The following is a description of a gene set: Mouse Gene Set: GOBP_REGULATION_OF_CATABOLIC_PROCESS species: Mus musculus Any process that modulates the frequency, rate, or extent of the chemical reactions and pathways resulting in the breakdown of substances., and this is the list of marker genes: Dapk1, Rnasel, Trim32, Rad23a, Rnf31, Gpr137b, Ythdf1, Usp25, Rybp-ps, Gsk3b, Ddit4, Mettl1, Myd88, Slfn2 (NCBI Gene Id 20556), Bag3, Lrsam1, Oaz3, Hmox1, Srebf1, Tecpr1, Amer1, Bag5, Pik3c3, Itch, Snx30, Larp4b, Senp1, Trib3, Eif2ak3, C9orf72, Dcp1a, Mir196a-1, Sqstm1, Caml, Snx4, Tent5c, Usp33, Asb5, Kat2b, Rab39b, Fbxl4 (NCBI Gene Id 269514), Vps28, Sh3rf1, Atg16l1, Ier3, N4bp1, Ikbke, Bcl2l11, Gnai3, Adra1b, Gsk3a, Elapor1, Eif2ak1, C4bp, Pip4k2b, Zc3h12d, Nudt15, Fbxl20, Mir451b, Ndfip1, Hnrnpc (NCBI Gene Id 28125), Xbp1, Tspan17, Zfp418, Psmf1, Cttn, Hipk2, Irak3, Cdkn1b, Traf3ip2, Pttg1ip, Ikbkg, Tlr9, Araf, Hspa1b, Atm, Akt1, Il10, Bnip3, Pkp1, Kat5, Ins1, Magoh, Pik3c2a, Pabpn1l, Tmtc3, Mir7578, Psen1, Snx1, Chfr, Ubqln1, Xpa, Cidea, Pnldc1, Plekhg5, Tent4a, Ptk2b, Tbk1, Ripk2 (receptor (TNFRSF)-interacting serine-threonine kinase 2), Wnk1, Nos2, Phkg1, Atg2a, Agap2, Nrde2, Moap1, Trim39, Pfkfb1, Mir451a, Bnip3l, Hsf1, Mad2l1, Rab7, Cpt1a, Tfeb, Mov10, Klhl22, Adam8, Dab2ip, Nkd2, Fhit, Fastkd1, Wdr6, Trim30a, Gata4, Fyco1, Anxa2, Rufy4, Slirp, Apc, Dcaf1, Pan2, Rchy1, Prkaa2 (protein kinase, AMP-activated, alpha 2 catalytic subunit), Hnrnpd, Ybx1, Zc3hav1, Trim3 (tripartite motif-containing 3), Nop53, Sec22b, Pias4, Pin1 (peptidyl-prolyl cis/trans isomerase, NIMA-interacting 1), Eif4a3l2, Bag2 (NCBI Gene Id 74827), Sgsm3, Dnm1l, Cacng7, Snx33, Adrb2, Psmd10, Msn, Abca2, Usp14, Tomm7, Csnk2a1, Trim71, Smarcc1, Samd9l, Hdac4, Atg12, Sf3b3, Ube2k, Sik2, Fmr1 (fragile X messenger ribonucleoprotein 1), Mir196b (NCBI Gene Id 723820), Igf2bp1, Lepr, Rragd, Sesn1, Pik3cg, Rbm38, Pkd1, Ager (advanced glycosylation end product-specific receptor), Rgp1, Zp3r, Trp53inp1, Trdmt1, Tent5a, Vgll4, Pbk, Pim2, Rbx1, Tmem168, Src, Traf7, Ythdf3, Tgfb1i1, Faf1, Fbxl2, Agbl4 (ATP/GTP binding protein-like 4), Csnk2b, Pabpc4, Serpine2, Cop1, Trim21, Fus, Lrrk2, Clu, Prxl2c, Fastk, Dact1, Tnfrsf1b, Cbfa2t3, Atg5, Mtm1, Eif4enif1, Mdm2, Rnf19a, Tigar, Det1, Hspb8, Herc1, Ubr4 (NCBI Gene Id 97189), Pptc7, Depp1, Apoc3, Endog, Dhx36 (NCBI Gene Id 99809, DEAH-box helicase 36), Pink1, Fastkd2, Rhbdd1, Abcb11, Nupr1, Cnot1, Nbas (NCBI Gene Id 71169), Ecscr, Ufl1, Rnf5, Ep300 (NCBI Gene Id 328572), Secisbp2, Mfsd8, Becn1, Rdx, Pcsk9, Adgrb1, Pkp3, Zfp36l3, Samd4, Bcl2, Kat8, Larp1, Pias1, Csnk2a2, Nanos1, Dysf, Tnrc6b, Smad4, Lrp1 (NCBI Gene Id 16971), Pum1, Sumo1, Tspo, Plk1, Apoc1, Aifm1, Srsf1, Hamp2, Zc3h18 (NCBI Gene Id 76014), Mir466l, Syncrip (NCBI Gene Id 78260), Socs4, Mtcl3, Supv3l1, Paqr3, Mlxipl (NCBI Gene Id 58805), Prkce, Fastkd3, Egfr, Disc1, Vegfa (vascular endothelial growth factor A), Mtor, Apex1, Nrg1, Igf2bp2, Nod2 (nucleotide-binding oligomerization domain containing 2), Noct, Dda1, Slc25a4, Cnr1, Rbm33, Ncor1, Dcps, Washc1, Klhl17, Wnt1, Tirap, Park7, Atf6, Fbxw7, Sirt6, Tardbp, Rps7, Ddit3, Lep, Pabpc1, Trf, Upf1, Usp38, Sh3rf2, Brf1, Dtl, Trim23, Ctsa, Oaz2, Styx-ps, Rnft2, Zfp36l1, Cd81 (NCBI Gene Id 12520), Setd2, Acacb, Ubqln2, Pacsin3, Atp5if1, Pcid2, Rhbdd3, Phf20l1, Tmem259, Tent4b, Pnpt1, Pnpla2, Phax, Rhbdf1, Egln1, Snx3, Smo, Ldc1, Pin1rt1, Trex1, Upf3a, Azin1, Psme3ip1, Vps35, Mycbp2, Psmd1, Dicer1, Mapt (NCBI Gene Id 17762), Cnot7, Igf1 (insulin-like growth factor 1), Wac, Ttc36, Tom1, Odc1, Prickle1, Ddb1, Sh3glb1, Wdr24, Sufu, Hcar2, Dffb, Sct, Lsm1, Stk38l, Twist1, Glmn, Slc4a4, Cul4b, Sco1, Jmjd8, Dapl1, Shh, Slc2a6, Cav1, Laptm4b, Phf23, Fbp1, Crebrf, Gata5, Optn, Daglb, Hsd11b1, Nsun2, Rbm47, Usp20, Mtdh, Zbtb20, Foxk2, Ambra1 (autophagy/beclin 1 regulator 1), Slc25a5, Gpc3, L3mbtl3, Angel2, Qrich2, Igtp, Etfbkmt, Mapkapk2, Parl, Rubcn, Abcd2, Mapk8, Tob1, Ptpn22, Ppp1r3d, Mlx, Atxn3, Prr5l, Sh3bp4, Gtsf1 (NCBI Gene Id 74174, gametocyte specific factor 1), Trem2, Nanos3, Tut7, Bmal1, Bmf, Mlycd, Acer2, Ldlr, Mtcl2, Usp13, Lrpprc, Ulk3, Gigyf2, Tbc1d25, Adra1a, Pten, Tmem9, Prmt6, Grin2c, Eif4g1, Egln2, Plk3, Svip, Sirt1, Snca, Nub1, Sirt2, Ubb, Rragb, Grsf1 (NCBI Gene Id 97246), Ttc5 (tetratricopeptide repeat domain 5), Fxr1, Axin1, Nnt, Trim65, Btrc, Sgta, Uchl5, Atg4b, Taf9, Rnft1, Nedd4, Casp1, Alk, Fmc1, Gtpbp1, Elavl4, Il6, Hpgd, Wnt5a, Adam9, Apoa4, Nampt, Bok, Atg7, Rock2, Zar1, Samd4b, Foxf2, Wdr41, Pcbp4, Hsp90aa1, Psme3, Cpeb3, Tmx1, Naf1, Cul4a, Gfap (NCBI Gene Id 14580), Ulk1, Socs5, Nkd1, Asb9 (NCBI Gene Id 69299), Dcn, Obp2a, Lonp2, Smurf1, Tpcn2, Zdhhc19, Sumo2, Dkc1, Hsp90ab1, Cidec, Slc4a1 (solute carrier family 4 (anion exchanger), member 1), Trib2, Psme2, Ifnb1, Fzr1, Esrrb, Dele1, Phka1, Kcne2, Polr2g, Nell1, Aurka, Phkg2, Flna, Actn3, Mtcl1, Aadac, Mex3d, Htra2, Cdh1, Trim13, Pan3, Dcaf12, Atg101, Csdc2, Apoa5, Serpinb1a, Gba1, Rab26, Apoe, Cers1, Cisd1, Dtx3l, Usp9x, Adra2a, Endou, Patl2, Pycard, Ppp1ca, Ptpn3 (NCBI Gene Id 545622), Piwil4, Mtln, Dnaaf4, E330034G19Rik, Tmf1, Rnf41, Lzts1, Elavl1, Itgb1, Ddrgk1, Trim67, Eif2a, Rptor, Atp6v0a1, Prkaca, Tpcn1, Npc1, Mettl14, Rmc1 (NCBI Gene Id 76482), Klhl40, Vps13c, Zc3h12a, Bag6, Usp30, Mettl3, Fkbp8, Apoh, Pde3b, Phb1, Prkag2 (NCBI Gene Id 73700), Zdhhc2, Ogt, Ppp1cb, Pde12, Tent5d, Mapk9, Idh1, Cnot2, Gja1, Usp8, Fmn2, Snx9, Pik3r2, Tut4, Rpl23, Wfs1, Il10ra, Prkd1 (protein kinase D1), Plin5, Usp26, Zfp36, Fap, Pip4k2c, Adora1, Rbm8a2, Rbm10, ENSMUSG00000144291, Gimap5, Il3, Ticam1, Fxr2, Dab2, Pik3r4, Ercc4, Tbc1d14, Prkaa1, Nlrp5, Ppara, Chuk, Cul3, Cptp, Qsox1, Zkscan3, Npm1, Alkbh5, Celf1, Zer1, Pip4k2a (phosphatidylinositol-5-phosphate 4-kinase, type II, alpha), Cdc37, Lats1, Rc3h2, Poldip2, E2f1, Thrap3, Foxo3, Scarb1, Golga2, Sorl1, Rock1, Plk2, Piwil2, Map2k1, Hnf4aos, Cnot6l, Sh3rf3, Mad2l2, Caprin1, Nprl3 (nitrogen permease regulator-like 3), Fabp1, Mtmr9, Eif4a3l1, Agtpbp1, Desi1, Scfd1, Abcd1, Ccny, Myog, Furin, Mgat3, Ubxn2a, Nfe2l1 (nuclear factor, erythroid derived 2,-like 1), Irs2, Snf8, Vip, Mylip, Ophn1, Hfe, Rab3gap2, Igfbp3, Uvrag, F8a, Rbm8a, Prkag1, Gdnf, Dbi, Ubqln4, Clec16a, Zfp36l2, Zmpste24, Mettl16, Vsir, Irgm1, Dcp1b, Mtch2, Cnot6, Mcl1, Csnk1a1, Tmem59, Arl2, Scoc, Trim63, Cnot3 (CCR4-NOT transcription complex, subunit 3), Tspan15 (tetraspanin 15), Tbrg4, Cyp51, Hk2, Azin2, Rb1cc1, Ifng, Foxo1, Timp2, Fbxo43, Uchl1, Mapk15, Piwil1, Tlr2 (NCBI Gene Id 24088), Pml, Nrdc, Dap, Fgf21, Eif3h, Slc11a1, Ikbkb, Rbm46 (RNA binding motif protein 46), Boll, Apoc2, Clstn3, Fto, Timp3, Eif6, Bax, Tiparp, Marchf7, Gabarapl2, Akt2, Ndufa13, Mlst8 (MTOR associated protein, LST8 homolog (S. cerevisiae)), Sox17, Rbx1-ps, Dram2, Ubxn1, Traf2, Zfand2a, Lrig2, Fyn, Rida, Cst3, Atraid, Bid, Vcp, Fn1, Slc25a12, Nmnat1, Rpl5, Dffa, Wdr45, Ric1, Rab8a, Sh3d19, Crtc3, Vim, Lin28b (NCBI Gene Id 69965), Ago3, Trim27, Adcy10, Vps11, Hif1a, Ppp1r3c, Carhsp1, Ptbp1, Dis3l2, Nedd4l, Tnrc6a, Atg14, Trim40, Rab3gap1, Usp7, Pafah1b2, Osbpl7, Ccdc22, Bcap31, Apoa2, Kdm4a, Mlh1, Ptk2, Fbxo11, Csnk1d, Fbxo2, Timp4, Rarres2, Tnfsf12, Cisd2, Stat3, Rragc, Mt3, Gabarap, Sgms1os1, Eif4g2, Traf5 (NCBI Gene Id 622602), Zbtb7a, Meioc, Cdk5rap3, Atg13, Dxo, Ppp1r3b, Gimap3, Scgb1a1, Parn, Dedd, Git1, Epm2a, Gpi1, Rnf139, Idua (NCBI Gene Id 269679), Casc3, Flcn, Ppargc1a, Ulk2, Plekhn1 (NCBI Gene Id 231002), Fbxo7, Apaf1, Rela, Plekhf1, Mfsd2a, Gna12, Foxk1, Khsrp, Ythdf2, Apobec1, Hdac6, Gpd1, Depdc5, Gga3, Taf15, Vdac1, Ppp2r3a, Irgm2 (immunity-related GTPase family M member 2), Hnrnpu, Enpp7, Cblb, Sptlc1, Cln3, Itga5, Gpx1, Ptpn1, Hnrnpr, Trp53, Supt5, Gck, Nanos2, Eif4a3, Sting1, Tspan5, Keap1 (NCBI Gene Id 54157), Arid5a, Dnajb2, Stx5a, Qki, Ezr, Ormdl3, Rnf180, Apoc2l, Tsc2, P2rx7, Rad23b, Ralb, Dlgap1, Snx7, Dazl, Acsl5, Tnfaip3, Erfe, Mir196a-2, Gclc, Rasip1, Tnrc6c, Dvl1, Snx12, Mefv, Arnt, Wdr91, Btg2, Rnf40, Cryba1, Nqo1, Hspa1a, Tmem132a, Commd1, Fastkd5, Il1b (interleukin 1 beta), Irgq, Ube3a, Smad3, Lamp3, Cdc20b, Calcr, Stk11, Cirbp, Axin2, Gga1, Trib1, Gpld1, Cdk16, Oaz1, Psen2, Il33, Bscl2, Aldob (aldolase B, fructose-bisphosphate), Hamp, Timp1, Prkcd, Magohb, Rpl11, Patl1, Slc7a5, Rbm24, Scarb2, Dnd1, Nrbp2, Prkag3, Tmem39a, Csde1, Rnf152, Vps13d, Pithd1, Wnt10b, Mdm4, Fez1, Il17a, Nod1, Igf2bp3, Hcar1, Slc35d3, Marchf2, Rraga, Chmp6, Nprl2, Cdkn2a, Kdr, Myc (myelocytomatosis oncogene), Sctr, Zdhhc7 (NCBI Gene Id 102193), Psme1, Xpo1, Ang, Herpud1, Pum2, App, Angptl3, Laptm5, Smcr8, Snx18 (NCBI Gene Id 218636), Hspbp1, Rc3h1, Sptlc2, Alad, Prkn, Cdc20, Mir144, Rybp, Rgma, Prkcg, Ddx49 (DEAD box helicase 49), Huwe1, Psmd2, Rnf185, Fbxw8, Ppp2ca, Zc3h14, Phkb, Styx, Gapdhs, Tysnd1, Ago2, Tnf, Ube2n, Insr, Trim8, Tent5b, Iigp1, Usp19, Sumo3, Gpsm1, Paip1, Dram1, Mapk3, Fam83d, Atp13a2, Nlrp6, Csnk1e, Map1a, Dhx34, Map3k7 (NCBI Gene Id 93774), Rilp, Tent2, Ago1, Fez2, Lypla1, Lpcat1, Cenatac, Usp10, Asb11, Ehmt2, Dcp2, Ins2, Chmp4b, Vhl, Deptor, Stub1, Htr2a, Ube2a, Bbs7, Hnrnpab, Rack1, Tmem67, Cnot8, Aqp11, Sesn3, Ppp1r3e, Fbxl5, Sesn2, Sox9, Zswim8, Nsf, Egf (NCBI Gene Id 99717), Fam76b, Zcchc17, Thra, Irs1, Atp2b4, Wipi1, A1cf, Psmd3, Il4 (interleukin 4), Calcoco2, Rab12, Ubr3, Fbxo22, Grin2a, Gpr137, Lmx1b, Ube2v2, Mid2, Serpinb1b, Nicol1, Pdcl3, Dhx9, Tsc1, Rgn, Ern1, Htt, Anks1, Hmgcr, Usp5, Hmgb1, Abhd5, Tlk2, Psmd14, Hnrnpa0, Gipc1, Pabir1, Mtmr2, Zyg11b, Ybx2, Mul1, Ccar2, Usp36, Chek2